The following is a description of a gene set: Human Gene Set: TFIII_Q6 studied in species Homo sapiens Genes having at least one occurrence of the motif RGAGGKAGG in the regions spanning 4 kb centered on their transcription starting sites. This matches the GTF2A1, GTF2A2 transcription factor binding site V$TFIII_Q6 (v7.4 TRANSFAC)., and this is the list of marker genes: MRC2, SH3BP5L, KLHL1, FOXG1, IL11, RAB35, ARHGAP44, RHBDL3, LMO4 (LIM domain only 4), SLC7A8, NFATC4, WDR81, LMNA, POU2F1, FFAR4, NDRG2, NCDN, PTCH2, FGF14, THRA, CBFA2T2, UBTF, PBX1, CYFIP1, TRIM46, CYGB, SHANK2, ERG28, BCL11A, POU3F3, LYL1, SBSN, FGF11, PSMC3IP, ZNF579 (NCBI Gene Id 163033), MYLK2, GNAS, MAP4K3, ELAVL3, ATXN7L2, CD44, FOXB1, CNNM1, FLI1, NLGN2, ARHGAP5, CDK15, FBXO36, ASCL1, CASKIN2, ZIC2, CA10, STRAP, FZD10, KRTCAP2, RARG, CAPN1, HOXD11 (NCBI Gene Id 3237), CAPN5, HOXC5, MIR22HG, MSI1, PKP3, SIN3A, NKX2-2, ADIPOR2, GPR162, MAFB, BCAT2, NODAL, ANP32A, CATIP (ciliogenesis associated TTC17 interacting protein), NR2F2, DGKZ, LRP3, MMD, SYT7, INHA, ESRRG, CBX4 (chromobox 4), PI4KB, UTP18, NKX2-1 (NK2 homeobox 1), TFAP4, UPF2, PLXNC1, CELF4, RHBDL2, LDB1, SIX4 (SIX homeobox 4), ABCC6, TNFSF12, NXPH3 (NCBI Gene Id 284079), NUTF2 (nuclear transport factor 2), JPH3, GGN, PHF23, UNC119, IRS1, CDK12, TCF7L1, ZNF143, SALL1, STX1B, GATA3, CHRM1, SP7, EHBP1, APC2, HCFC1R1, S1PR1, TSPAN2, ATP1A2, CTNNBIP1, CNTN2, BCL2L2, KPNB1, MICAL2, HOXC11, BAHD1, ZNF580, WNK4, NR1H3, VSIG2, CALM2, CORO1C, FCHSD2, ZMYND8, APPBP2, PPP1R9B, TMEM86A, C1orf21, PAX9, JAG1, TFB2M, RCOR2, MEOX1, ADAM11 (ADAM metallopeptidase domain 11), SF1, TSEN54, PCDH9, ST3GAL2, PPP2R5E, CKMT1B, ITGA3, RPS6KA5, IL34, PAX2, PAFAH1B1, VPS13C, POLR1G, KCNH3, BMF, ZNF263, SMG7, RAB5B, HJV, HOXC10, TCF12, CRTC2, LMO3, PSME3, NPTN (neuroplastin), SPRED2, FAM20A, ALX3, SIX5, LIN28A, JUP (junction plakoglobin), MTA2 (metastasis associated 1 family member 2), FOXA2, KCNJ10, PPIG, NNAT, HCAR1, STAT3, CELF1, SOX13, PHF13, MAX, OSR1, PCGF2 (NCBI Gene Id 7703), EMX2, BCL9L, TNFSF12-TNFSF13, NCOA6, MPC2, XPO1, SHISA6, RORC, NAB2, ADAM10, LRP1, THOC6, FEV, BAZ2A, PRRX1, EED, TGFB3, PAX1, NFIX, YPEL4, MAF, CNST, HTN1, WDTC1, CCND2